The following is a description of a gene set: studied in species Mus musculus Mouse Gene Set: GOBP_REGULATION_OF_NERVOUS_SYSTEM_DEVELOPMENT Any process that modulates the frequency, rate or extent of nervous system development, the origin and formation of nervous tissue., and this is the list of marker genes: Xrcc4, Mfn1, Dusp10, Bhlhb9, Bmp2, Dlx1, Drd2, Ctsc, Dbn1, Sh3glb1, Dnm1l, Nkx2-2os, Otp, Amigo3, Shox2, Tspo, Yap1, Lingo4, Plag1, Hmga2, Elapor2, Notch1, Bcl11a, Ufl1 (UFM1 specific ligase 1), Lingo2, Megf8, Tnr, Pard3, Il6, Fzd4, Mbp, Il33, Sorl1, Etv5, Neurl1a, Sema4a, Abcc8, Nrg1, Afdn, Ldlr (low density lipoprotein receptor), Crabp2, Wnt3a, Ferd3l, Man2a1, Grid2 (NCBI Gene Id 94324), Nap1l1, Bag1, Met, Lrtm1, Flrt3, Plxnb3, E2f1, Slitrk5, Zfp488, Slitrk2, Dlg5, Rxrg (retinoid X receptor gamma), Lrrn1, Map6, Camk2b, Cul7, Prkci, Tg, Adgrb3, Mbd1, Dmrta2, Dynlt1b, Lrrtm4, Lef1, Dnajb11, Eif2ak3, Trim32, Ptpra, Zfp335, Numbl, Hdac6, Ndel1, Ptn (NCBI Gene Id 19242), Mdga1, Rassf10, Igf1 (NCBI Gene Id 320499), Thbs2, Cit, Pten, Adgrl2, Fig4, Fbxo31, Fezf2, Adgrl4, Arhgap32, Cdon, Nrdc (NCBI Gene Id 76534), Cbln2, Cip2a, Stk11, Mt3, Slitrk4, Rgma, Pou4f1, Adgrl1, Ascl2, Itgb1, Thy1, Epha4, Caprin2, Prl2c2, Wnt5a, Kdm4a, Rela, Brinp1, Pak3 (NCBI Gene Id 18481), Zcchc24, Sema3g, Ccl11, Fezf1, Xrcc6, Syt4, Sema5a, Sema6c (NCBI Gene Id 20360), Mir219a-1, Tpbg, Rtn4r, Ppp3ca, Adgrb2, Ncmap, Heyl, Ntrk2, Trpc5, Lrrc4b, Rufy3, Rab21, Gpr37l1, Nrp1, Atoh1, Olig2, Grip1, Hes1, Sox8, Hook3, Aspa, Plxnc1, Fxn, Prkca, Robo1, Nf2, Pax6, Dip2b (NCBI Gene Id 239667, disco interacting protein 2 homolog B), Lrp8, Dll4, Twf2, Shank3, Nlgn1, Epha7, Trpv2, Khdc3, Dock7, Sox11 (NCBI Gene Id 67779), Cux1, D130043K22Rik, Tenm4, Srf, Pitx3, Pou4f2, Syngap1, Ptprd, Star, Ephb3, Ptpn13, Lyn, Iqsec1, Mir219a-2, Lgi4, Robo2, Vegfc, Prpf19 (pre-mRNA processing factor 19), Pparg, App, Gh, Nlgn3, Cxcl12, Dll1, Casz1, Smo, Ptprs, Sema3f, Fmr1, Synj1, Rest, Ilk, Hey2 (NCBI Gene Id 30802), Baiap2, Arhgap4, Tgfb1, Vim, Id1, Fgfr3, Cdh1, Tcf7l2, Nr1d1, Pak1, Fxr2, Macf1, Srebf2, Ephb2, Lpar3, Tlr2, Skil, Mapt, L1cam, Srrt, Nf1, Clcf1, Kdm1a, Trem2, Kif14, Plxnb2 (plexin B2), Tiam2, Numb, Vegfa, Tlx2, Clstn1, Itpka, Lif, Dicer1, Rnf112, Ywhah, Map1b, Tppp, Cdkl5, Ss18l1, Sgms1os1 (Sgms1 opposite strand transcript 1), Lrp2, Bdnf, Dkk1 (NCBI Gene Id 13380), Enpp2, Shh, Dscam (DS cell adhesion molecule), Ccr5, Bmp7, Wasf3, Rb1, Il1rap, Syndig1, Lhx2, Tsc2, Efna5, Dab1, Ythdf2, Cdkn2b, Iqsec2, Arrb2, Xrcc5, Ngf, Tymp, Ptprf, Anxa2, Lig4, Ptk2, Mup20, Prmt5, Slit2, Ngfr, Fzd3, Ctdsp1, F2, Cdkl3, Actr3, Wls, Ryk, Serpinf1 (NCBI Gene Id 20317), Xrcc2, Ptprz1, Hif1a, Amigo2, Cdk18, Tert, Hes3, Lrrc24, Lrrtm2, Mfn2, Mir124a-3, Myrf, Slit1, Bmpr2, Fgf2, Il6st, Nptn, Mycn, Islr2, Tnfrsf21, Kifap3, Lrtm2, Gjc2, Gorasp1, Rnf10, Csf1r, Bin1, Spint1, Srpx2, Mecp2, Wnt7a, Nr2e1, Hey1, Drd3, Adgre5, Nsun5, Mme, Tnf, Bmpr1a, Bhlhe41, Tle6, Dixdc1, Per2, Mir23a, Sox10, Gfap, Flt1, Hdac2, Ephb1, Adcyap1, Rxra, Actr2, Slc7a5, Helt, Tnfrsf12a, Ascl1, Lrrtm1, Dlx2, Plxnb1, Disc1, Snw1, Ntrk3, Akt1, Spart, Bmal1, Kras, Smarcd3, Cbln1, Nfatc4, St8sia2, Nin, Picalm, Obsl1, Trpc6, Lingo1, Anapc2, Tiam1, Flrt2, Ankrd27, Cdh4, Flrt1, Cx3cr1, Bex1, Egr2 (NCBI Gene Id 13654), Ist1, Atxn1, Rhoa, Rtn4, Sox2, Fgf13, Sema7a, Trf, Gsk3b (NCBI Gene Id 98033), Ezh2, Zfyve27, Eef2k, Il1rapl1, Tnfrsf1b, Ace, Wnt3, Appl2, Serpine2, Hes6, Ttc3, Parp6, Clcn2, Plxnd1, Ntrk1, Atf5, Lrp4, Zfp365, Kit, Lpin1, Prox1, Ep300, Prtg (protogenin), Fn1, Cd24a, Golga4 (golgin A4), Ntn1, Cers2, Zpr1, Gata2, Golga2, Btg2, Ell3, Dbnl, Ube2v2, Cdk5, Slitrk3, Cysltr2, Il1b, Lrp1, Rara, Gsx2, Stau2, S100a10, Pcm1, Reln, Aspm, Dag1, Nlgn2 (neuroligin 2), Id4, Trak2, Egfr, Grm5, Rpl4, Map3k13, Vax1, Vstm5, Psen1, Marcks, Caprin1, Ulk2, Gbx1, Trak1, Draxin, Arhgef2, Myb, Amigo1, Hnrnpk (heterogeneous nuclear ribonucleoprotein K), Faim, Bmp4, Slitrk6, Kctd11, Stk25, Map2k2, Tgm2 (transglutaminase 2, C polypeptide), Vsx2, Wnt7b, Pias2, Xlr3b, Nos1, Zeb2, Clstn3, Idh2, Rarg, Ache, Lta, Dct, Rxrb, Prkch, Hes7, Fxr1, Adgrl3, Cask (calcium/calmodulin dependent serine protein kinase), Lin28a (lin-28 homolog A), Hltf, Hap1, Hoxb3, Lrrn3, Ctnna1, B2m, Tbc1d24, Apoe, Trim11, Oxtr, Cdh2 (cadherin 2), Cyfip1, Oxt, Cxcr4, Gli3, Dll3, Sema4d, Lrrtm3, Map2, Sema3a, Akap5, Kdr, Daam2, Hmgb2, Tmem98, Ski, Rarb, Gdi1, Hdac1, Adcy10, Wnt2, Opa1, Chd7, Sirt2, Kalrn, Spen, Ifng, Smurf1, Trp53, Myo5b, Rnd2, Trp73, Cx3cl1, Clstn2, Agrn, Prune1, Ctnnb1, Rgs14, Rnf6, Mag (NCBI Gene Id 17136), Dhx36, Adgrb1, Id2, Gper1, Mir124a-1, Myc, Jam2, Shtn1, Braf, Qki (NCBI Gene Id 66145), Nkx6-2, Pafah1b1, Wdr62, Sema4f, Nrxn1, Hgf, Chodl, Nefl, Pik3r1, Ctf2, Slc25a12, Tnik, Foxg1, Map2k1, Mapk8 (mitogen-activated protein kinase 8), Dlg1, Oprm1, Hes5, Mir124a-2, Sema6d, Snap91, Fas, Cux2, Fbxw8, Mtmr2, Adnp, Ifrd1, S100b, Slitrk1, Metrn, Eif2b2, Cst7, Itgax, Efnb3, Nog, Eif4g2, Gbx2, Dlg4, Nkx2-2 (NCBI Gene Id 228734), Fstl4, Cysltr1 (cysteinyl leukotriene receptor 1), Rapgef2, Dpysl5, Musk, Sgk1, Ghrl, Il34, Ntf3, Ulk1, Hes2, Nkx6-1, Bhlhe40, Mtor, Slc30a1, Dcx (NCBI Gene Id 13193), Ppp1cc, Plxna3, Mdk, Limk1, Trim46 (tripartite motif-containing 46), Rheb, Asic2, Jade2